The following is a description of a gene set: Genes upregulated in subsets of cells of a given type within various tumors In this study, an extensive analysis was conducted to define meta-programs (MPs) capturing intra-tumor heterogeneity across a spectrum of tumor types. The approach utilized non-negative matrix factorization (NMF) to analyze each cell type separately within individual tumor samples. This involved the analysis of malignant cells, macrophages, fibroblasts, endothelial cells, epithelial cells, T-cells, and B-cells. NMF was executed with varying parameter values (K=4, 5, 6, 7, 8, 9), thereby generating 39 programs for each cell type per sample. Each NMF program was summarized by the top genes based on NMF coefficients.\nRobust MPs were then delineated for each cell type using a set of stringent criteria, including recurrence within the same tumor, similarity to programs in other tumors, and non-redundancy within a tumor. Subsequently, these robust NMF programs were clustered (per cell type) based on Jaccard similarity, leading to the identification of MPs associated with each cell type.\nTo enhance the quality of the MPs, a refinement steps were undertaken, involving the removal of MPs suspected of reflecting low-quality data (with an overrepresentation of ribosomal proteins or mitochondrial-encoded genes), single-study inclusion, or similarity to miss-annotated cell types. from publication Gavish A, Tyler M, Greenwald AC, Hoefflin R, Simkin D, Tschernichovsky R, Galili Darnell N, Somech E, Barbolin C, Antman T, Kovarsky D, Barrett T, Gonzalez Castro LN, Halder D, Chanoch-Myers R, Laffy J, Mints M, Wider A, Tal R, Spitzer A, Hara T, Raitses-Gurevich M, Stossel C, Golan T, Tirosh A, Suvà ML, Puram SV, Tirosh I (PMID 37258682) species: Homo sapiens Human Gene Set: GAVISH_3CA_MALIGNANT_METAPROGRAM_15_EMT_4, and this is the list of marker genes: C1S, SERPINE2, CAV1, COL17A1, CCL2, THBS2, ASS1, SPARC, SESN3, CXCL14, DAPL1, C12orf75, C1R, KRT15 (NCBI Gene Id 3866), SNHG32, HTRA1, SFRP1, DST, SDCBP, PNRC1, SERPINH1, TP53AIP1, SOX4, FTH1, LTF, SLC47A2, SELENOP, DCN, TIMP1, ALDH3A1, EGR1, GLUL, BCAM, TSC22D1, TXNIP, NCOA7, MOXD1, CD74, NINJ1, IFITM1, HOPX, ANTXR1, ASPN, NTRK2, SNAI2, SERPINF1, IFIT3, SOCS3, NFIB, IGFBP5